The following is a description of a gene set: Prominent forehead studied in species Homo sapiens Human Gene Set: HP_PROMINENT_FOREHEAD Forward prominence of the entire forehead, due to protrusion of the frontal bone., and this is the list of marker genes: ELN, ARCN1, ADAT3, PITX2, DRG1, COL27A1, RYR3, H3-3A, ATIC, PROP1, RPS6KA3, PMM2, PKDCC, NEXMIF, CEP57, SKI, D2HGDH, RAI1, KPTN, DPF2, ZNF711 (zinc finger protein 711), HRAS, H3-3B, RRAGC, SH3PXD2B, SLC2A1, MARS2, ALX4, BRWD3, PUF60, SATB2, INPP5E (inositol polyphosphate-5-phosphatase E), DPYD, PIGL, VPS35L, IGF1, CPT2, ITGA3, KIF7, GNE (NCBI Gene Id 81868), ERMARD (ER membrane associated RNA degradation), AMER1, RAF1, SNX14, AP2M1, EDA, PRMT7, LRPPRC, ALDH18A1, CASK, FBLN5 (fibulin 5), OPHN1 (oligophrenin 1, NCBI Gene Id 4983), VPS33A, SMG9, FAT4, DPH5, STAT3, IL2RA, GNS, PEPD, LARP7, LRP4, CKAP2L, ZBTB7A, CTCF, HMGA2, HERC1, FGFR1, KDF1, LBR (NCBI Gene Id 653311), IFT140, PEX5, PPP2R5D, HESX1, SKIC3, EDARADD, SP7, RECQL4, SUMF1, SERPINH1, ZNF292, MTOR, FBN1, AGR2, AP1G1, CAMK2B, FLNA, KMT2D (lysine methyltransferase 2D), TRIP11, DPH1, RTL1, USP9X (NCBI Gene Id 8239), MBTPS1, PTH1R, B3GAT3, TWIST1, PIK3R1, NRAS, CNTNAP2, CHST3, GLI2, IL6ST, SMOC1, CBFB, NANS, MEGF8, EXT2, PAM16, FBXL4, MYCN, GPAA1, PLA2G6, CDKN1C, IFT81, CCND2, NSD1, SYNGAP1, PDGFRB, TAPT1, ZSWIM6, FARSB (phenylalanyl-tRNA synthetase subunit beta), MAB21L2, CREBBP, DVL3, MAPKAPK5, H19, SRPK3, PIGK (phosphatidylinositol glycan anchor biosynthesis class K), ZBTB20, SCYL2, MN1, DLK1, IGF2, EFEMP2, SPECC1L, FAM50A, ASXL1, KIAA0753, RMRP, PRPS1, DVL1, SIN3A, GJA5, TBCE, DPH2, THSD1, MED12, COL2A1, FLNB (filamin B), SRCAP, KIF11, ERF, RYR1, CHD3, FGFR3, COG4, UNC80, FOXC1, ZPR1, PLAG1, POC1A, WASHC4, FBXO31, BRAF, P4HTM, KMT2A, ZBTB18, KIDINS220, DHCR24 (NCBI Gene Id 9800), EDAR, GJA8, KDM6B, HECTD4, AP1S2, GPC4, GJB6, B3GALT6, EPG5, CRELD1, JARID2 (NCBI Gene Id 3720), TMEM147, FMR1, SETBP1, SON, FAM111A, TRRAP, KCNJ1 (potassium inwardly rectifying channel subfamily J member 1), ROR2, TMEM53, DYNC1H1, FUCA1, IARS2, HECW2, RALA, EBF3, LHX4, KDM1A, NPR2, PTEN, WNT5A, EXOSC2, CHD2, SVBP, NAA10, ABCC9 (NCBI Gene Id 102724274), UPF3B, UBR7 (NCBI Gene Id 55148), KMT2E, ZFX, TAF1, WAC, NFIX, OBSL1, NALCN, TTC7A, MED13L, SCN1A, SHOC2, MYH3, ASXL3, SLC6A1, INPPL1, PRKAR1A, ACTL6B, PDE4D, ARNT2, CDC42, POLR3A, PRKDC, STAT5B, TONSL, SETD2, PURA, TRAF6, PPP1CB, CLCN3, FZD2, CNOT3, MID1, FOXP1, PYCR1, SKIC2, POU1F1, GLE1, FGFR2, FAM149B1, B3GLCT, CA2 (NCBI Gene Id 760), SUZ12, CDKL5, COL18A1, MAN2B1, GJB2, APC2, MEG3, ADNP, GOLGA2, CDH2, PTDSS1, NSD2, GRB10, LHX3, EP300, IRX5, ARX